Given this list of marker genes Cd4, Calu (calumenin), Cln6, Wnt6, Ptgs2, Ces1e, H6pd, Lyz2, Edem3, Clu, Ppib, Txndc5, Minpp1, Ntf5, Pcsk2, Ces3b, Serpinh1 (serine (or cysteine) peptidase inhibitor, clade H, member 1), Wnt5b, Fkbp7, Casq1, Wnt3a, Rnaset2a, Pdia4, Vkorc1, Pdia2, Pcsk5, Wnt4, Ache, Uggt1, Hsp90b1, Ero1b, Poglut2, Gbf1, Os9, Pdia5, Sumf2, Rdh5, Ces1d, Ins2, Pdia3, Tbxas1, Casq2, Cercam, Pcsk7, Wnt1, Ptgis, Tmem43, Pdia6, Rdh16, Dnajc1, Fkbp14, Vtn, Slc27a2, Entpd5, Rcn1, Sumf1, Rnaset2b, Lyz1, Mzb1, Chil3, Ces1c, Dnajb9, Wnt7b, P4ha3, Tor2a, Srl (sarcalumenin), Wnt5a (wingless-type MMTV integration site family, member 5A), Dnajc10, Ccdc134, Colgalt1, Edem2, Poglut1 (NCBI Gene Id 22429), Flt3, Erlec1 (NCBI Gene Id 66753), Il12a, Tor4a, Il12b, Txndc16, Resp18, Jmjd8, Fkbp10, Furin, Ptprn2, Eogt, Tor3a, Tor1b, Foxred2, Calr, Sdf2l1, Edn1 (NCBI Gene Id 13614), Pcsk9, Bdnf, Erp29, Pcsk1, Ces1g, Hyou1, Rcn2, Erp44, Pcsk4 (NCBI Gene Id 97673), Ces3a, Erap1, Plod3, Poglut3, P4ha2 (procollagen-proline, 2-oxoglutarate 4-dioxygenase (proline 4-hydroxylase), alpha II polypeptide), Wnt3, Fkbp9 (FK506 binding protein 9), Selenom, Selenof, Cyp2w1, Rcn3, Ins1, Ggcx, Ptgs1, Calr3, Txndc12, Bche, Ptgds, Dnajb11, Sil1, Ntf3, Manf, Lrpap1, Wnt7a, Colgalt2, Hspa5, P4hb (NCBI Gene Id 18453), Ngf, Tor1a, P4ha1, Dnajc3, Shh, Erp27, here is a description of the gene set: species: Mus musculus Mouse Gene Set: GOCC_ENDOPLASMIC_RETICULUM_LUMEN The volume enclosed by the membranes of the endoplasmic reticulum.